Given this list of marker genes RXRA, INHA, RARA, MOV10, TCF4, INHBA, ARRB1, GIPC1, TGFB1, MMP16, NCSTN, PSEN1, PSEN2, AGO3, PSENEN, MYOG, TIMP1 (TIMP metallopeptidase inhibitor 1), TCF12, TCF3, MYCN, AGO1, TNRC6A, MYF5, HELLS, FGF2, SP1, TNRC6C, TGFBR2, TGFB2, TGFBR1, AGO4, SMAD3, MIR23B, MIR27B, EP300, APH1B, MIRLET7A1, MMP14, KLF16, TGFBR3, MYF6, MYOD1, ACVR2A (NCBI Gene Id 92), APH1A, ARRB2, AGO2, SMAD4, TIMP2 (NCBI Gene Id 7077), TNRC6B, here is a description of the gene set: Human Gene Set: REACTOME_SIGNALING_BY_TGFBR3 Signaling by TGFBR3 studied in species Homo sapiens